The following is a description of a gene set: The tumoral clone of Waldenström's macroglobulinemia (WM) shows a wide morphological heterogeneity, which ranges from B lymphocytes (BL) to plasma cells (PC). By means of genome-wide expression profiling we have been able to identify genes exclusively deregulated in BL and PC from WM, but with a similar expression pattern in their corresponding cell counterparts from chronic lymphocytic leukemia (CLL) and multiple myeloma (MM), as well as normal individuals. The differentially expressed genes have important functions in B-cell differentiation and oncogenesis. Thus, two of the genes downregulated in WM-BL were IL4R, which plays a relevant role in CLL B-cell survival, and BACH2, which participates in the development of class-switched PC. Interestingly, one of the upregulated genes in WM-BL was IL6. A set of four genes was able to discriminate clonal BL from WM and CLL: LEF1 (WNT/beta-catenin pathway), MARCKS, ATXN1 and FMOD. We also found deregulation of genes involved in plasma cell differentiation such as PAX5, which was overexpressed in WM-PC, and IRF4 and BLIMP1, which were underexpressed. In addition, three of the target genes activated by PAX5 - CD79, BLNK and SYK - were upregulated in WM-PC. In summary, these results indicate that both PC and BL from WM are genetically different from the MM and CLL cell counterpart. studied in species Homo sapiens from publication Gutiérrez NC, Ocio EM, de Las Rivas J, Maiso P, Delgado M, Fermiñán E, Arcos MJ, Sánchez ML, Hernández JM, San Miguel JF (PMID 17252022) Human Gene Set: GUTIERREZ_WALDENSTROEMS_MACROGLOBULINEMIA_1_UP Genes exclusively up-regulated in B lymphocytes from WM (Waldenstroem's macroblobulinemia) patients but with a similiar expression pattern in the normal cells and in the cells from CLL (chronic lymphocytic leukemia) patients., and this is the list of marker genes: GABBR1, ITPR1, IL4R, ADARB1, ADAM28, APLP2, BACH2, ABCB4, SESN1, ABCB1